Given this list of marker genes RBM4, SRRT (NCBI Gene Id 51593), AQP9, DHX36, CYP1A1 (cytochrome P450 family 1 subfamily A member 1), SERPINF1, CPOX, RNF4, ALAD, GRIA1, FECH, UROS, DDX3X (NCBI Gene Id 730543), ZC3H12A, PPIF, ATR, GCLC, ZFAND2A, MAPK13, HMOX1, VCP, GSTO1, SLC38A2, NEFL, ZFAND1, GSTO2, MKNK2, HSF1, HNRNPA1, DAXX, here is a description of the gene set: Human Gene Set: GOBP_RESPONSE_TO_ARSENIC_CONTAINING_SUBSTANCE species: Homo sapiens Any process that results in a change in state or activity of a cell or an organism (in terms of movement, secretion, enzyme production, gene expression, etc.) as a result of an arsenic stimulus from compounds containing arsenic, including arsenates, arsenites, and arsenides.